Given this list of marker genes VPS37D, CHMP5, MVB12B, VPS4A, UBA52, CHMP2B, VPS28, CHMP3, RPS27A, VPS4B, HGS, SNF8, VPS37A, CHMP4C, UBAP1, VTA1, CHMP4B, MVB12A (multivesicular body subunit 12A), STAM2, CHMP4A, VPS37C, STAM, VPS25, VPS37B, CHMP6, CHMP2A, CHMP7, TSG101, UBB, UBC (ubiquitin C), VPS36, here is a description of the gene set: Reactome Pathway: Endosomal Sorting Complex Required For Transport (ESCRT) Many plasma membrane proteins are in a constant flux throughout the internal trafficking pathways of the cell. Some receptors are continuously internalized into recycling endosomes and returned to the cell surface. Others are sorted into intralumenal vesicles of morphologically distinctive endosomes that are known as multivesicular bodies (MVBs). These MVBs fuse with lysosomes, resulting in degradation of their cargo by lysosomal acidic hydrolases.<br> Endosomes can be operationally defined as being either early or late, referring to the relative time it takes for endocytosed material to reach either stage. Ultrastructural studies indicate that early endosomes are predominantly tubulovesicular structures, which constitute a major sorting platform in the cell, whereas late endosomes show the characteristics of typical MVBs and are capable of fusing with lysosomes.<br> A well characterized signal for shunting membrane proteins into the degradative MVB pathway is the ubiquitylation of these cargoes. At the center of a vast protein:protein and protein:lipid interaction network that underpins ubiquitin mediated sorting to the lysosome are the endosomal sorting complexes required for transport (ESCRTs), which are conserved throughout all major eukaryotic taxa. species: Homo sapiens part of: Membrane Trafficking